The following is a description of a gene set: Human Gene Set: IKEDA_MIR133_TARGETS_UP Genes up-regulated in hypertrophic hearts (due to expression of constitutively active form of PPP3CA) and predicted to be targets of miR-133 microRNA. species: Mus musculus from publication Ikeda S, He A, Kong SW, Lu J, Bejar R, Bodyak N, Lee KH, Ma Q, Kang PM, Golub TR, Pu WT (PMID 19188439) Calcium signaling is a central regulator of cardiomyocyte growth and function. Calmodulin is a critical mediator of calcium signals. Because the amount of calmodulin within cardiomyocytes is limiting, the precise control of calmodulin expression is important for the regulation of calcium signaling. In this study, we show for the first time that calmodulin levels are regulated posttranscriptionally in heart failure. The cardiomyocyte-restricted microRNA miR-1 inhibited the translation of calmodulin-encoding mRNAs via highly conserved target sites within their 3' untranslated regions. In keeping with its effect on calmodulin expression, miR-1 downregulated calcium-calmodulin signaling through calcineurin to NFAT. miR-1 also negatively regulated the expression of Mef2a and Gata4, key transcription factors that mediate calcium-dependent changes in gene expression. Consistent with the downregulation of these hypertrophy-associated genes, miR-1 attenuated cardiomyocyte hypertrophy in cultured neonatal rat cardiomyocytes and in the intact adult heart. Our data indicate that miR-1 regulates cardiomyocyte growth responses by negatively regulating the calcium signaling components calmodulin, Mef2a, and Gata4., and this is the list of marker genes: CDC42, YWHAQ, SLC6A6, EIF4G3, ASPH, CTBP2, ELAVL1, SEC61B, SLC23A2, DNAJB6, NCOA6, SNX1, GNAI3, NDRG1, DDX3X, ACTR3 (actin related protein 3), RABGAP1, ARPC5, AKAP9 (NCBI Gene Id 10582), SGPP1, PPP2CA, FMNL2, PTPRO, RBMX, EBF2, HS2ST1, RBPJ, MYH9, SACM1L, PTPRD, RAP2C, PITPNB, HIF1A, GPC6, USP32, APPBP2, PPP1R12A, MAML1, RAPH1, LHFPL6, NFAT5, MAFK, ANKRD12, CYLD